The following is a description of a gene set: studied in species Mus musculus The orderly movement of a cell from one site to another that will contribute to the progression of the heart over time, from its initial formation, to the mature organ. Mouse Gene Set: GOBP_CELL_MIGRATION_INVOLVED_IN_HEART_DEVELOPMENT, and this is the list of marker genes: Edn1, Nrp1, Ndrg4, Dchs1, Eng, Cdc42, Sema3c, Bves (NCBI Gene Id 23828), Ednra, Flrt3 (fibronectin leucine rich transmembrane protein 3), Bmp4, Pdgfrb, Pitx2, Notch1, Twist1, Mesp1, Bmp7, Snai2, Hand2, Folr1